The following is a description of a gene set: Human Gene Set: GOBP_NUCLEOTIDE_SUGAR_METABOLIC_PROCESS studied in species Homo sapiens The cellular chemical reactions and pathways involving nucleotide-sugars, any nucleotide-carbohydrate in which the distal phosphoric residue of a nucleoside 5'-diphosphate is in glycosidic linkage with a monosaccharide or monosaccharide derivative., and this is the list of marker genes: UGP2, MPI, GSK3A (glycogen synthase kinase 3 alpha), SLC35A3, GNE, UGGT2, UAP1L1, SLC35C1, CMAHP, GFPT1, PARG, FCSK, GFUS, B4GALNT2, NANP, GNPNAT1, SLC35A1, GFPT2, GUK1, FUOM, HK1, GNPDA1, PGM3, NAGK, GMPPA, GMDS, UAP1, UGDH, PMM2, EXTL2, MGAT1, GALT, AMDHD2, CSGALNACT1, NANS, TGDS, FPGT, PMM1, GNPDA2, DPM1, FUT8, ENTPD5, CMAS, UXS1, GMPPB, UGGT1